The following is a description of a gene set: species: Mus musculus This event has been computationally inferred from an event that has been demonstrated in another species.<p>The inference is based on the homology mapping from PANTHER. Briefly, reactions for which all involved PhysicalEntities (in input, output and catalyst) have a mapped orthologue/paralogue (for complexes at least 75% of components must have a mapping) are inferred to the other species. electronically inferred by orthology from the curated human pathway Reactome Pathway: Translesion synthesis by REV1 part of: Translesion synthesis by Y family DNA polymerases bypasses lesions on DNA template, and this is the list of marker genes: Rpa1, Rfc1, Mad2l2, Pcna, Rev3l, Rfc3, Rps27a (ribosomal protein S27A), Ubb